Given this list of marker genes TNFRSF11B, MT-CO3, LPIN1, KL, CASR, PTH, GCM2, FAM111A, PRKAR1A, CLDN16, GNAS-AS1, OBSCN, GALNT3, GNAS, TBCE (NCBI Gene Id 6905), RYR1, GNA11, MIR140, CACNA1S, STX16, MT-CO1, here is a description of the gene set: studied in species Homo sapiens Human Gene Set: HP_HYPERPHOSPHATEMIA An abnormally increased phosphate concentration in the blood. Hyperphosphatemia